Given this list of marker genes POU1F1, SECISBP2, MADD, TRHR, NKX2-5, here is a description of the gene set: A reduced concentration of free 3,3',5-triiodo-L-thyronine in the blood circulation. species: Homo sapiens Human Gene Set: HP_DECREASED_CIRCULATING_FREE_T3 Decreased circulating free T3